Given this list of marker genes CDKN2A, here is a description of the gene set: part of: Diseases of Cellular Senescence Reactome Pathway: Evasion of Oxidative Stress Induced Senescence Due to p14ARF Defects species: Homo sapiens One of the two main protein products of the CDKN2A gene, p14ARF (CDKN2A transcript 4, CDKN2A-4, ARF), contributes to oxidative stress induced cellular senescence by stabilizing TP53 (p53). The function of p14ARF in p53 stabilization through sequestration of MDM2, a p53 ubiquitin ligase, depends on the nuclear localization of p14ARF and its ability to interact with MDM2. The nuclear localization signal and the MDM2 interaction domain map to the first 15 amino acids of the N-terminus of p14ARF. This region is encoded by the p14ARF-specific exon 1beta of CDKN2A. An independent MDM2-binding domain is localized at the C-terminus of p14ARF. Insertion of 16 nucleotides in exon 1beta results in a frameshift truncation of p14ARF, responsible for a familial melanoma syndrome in which the p16INK4A product of the CDKN2A gene is unaffected. This mutation is rare and has so far been reported in one family only. The mutant protein, p14ARF V22Pfs*46 has the nucleotide localization signal and the N-terminal MDM2 interaction region preserved, but is unable to translocate from the cytosol to the nucleus, possibly due to aberrant conformation (Rizos, Puig et al. 2001), and also lacks the C-terminal MDM2 interaction region. Relocation of wild type p14ARF to the cytosol has been observed in melanoma (Rizos, Darmanian et al. 2001) and aggressive thyroid papillary carcinoma. Genomic deletion of exon 1beta, with exons 1alpha, 2 and 3 intact, has been reported in about 30% of melanoma cases with genomic deletions involving the CDKN2A locus. Several different familial melanoma germline mutations map to the exon 1beta splice donor site.<br>The ability of p14ARF to localize to the nucleolus also plays a role in p14ARF-mediated stabilization of p53. Mutations in exon 2 of the CDKN2A gene can lead to missense mutations in p14ARF that affect its nucleolar localization and p53 stabilization, but the exact mechanism has not been fully elucidated.